The following is a description of a gene set: Human Gene Set: GSE2770_TGFB_AND_IL4_VS_IL4_TREATED_ACT_CD4_TCELL_6H_DN from publication Lund R, Aittokallio T, Nevalainen O, Lahesmaa R (PMID 14607935) species: Homo sapiens Th1 and Th2 cells arise from a common precursor cell in response to triggering through the TCR and cytokine receptors for IL-12 or IL-4. This leads to activation of complex signaling pathways, which are not known in detail. Disturbances in the balance between type 1 and type 2 responses can lead to certain immune-mediated diseases. Thus, it is important to understand how Th1 and Th2 cells are generated. To clarify the mechanisms as to how IL-12 and IL-4 induce Th1 and Th2 differentiation and how TGF-beta can inhibit this process, we have used oligonucleotide arrays to examine the early polarization of Th1 and Th2 cells in the presence and absence of TGF-beta after 0, 2, 6 and 48 hours of polarization. Genes down-regulated in CD4 T cells activated by anti-CD3 and anti-CD28: TGFB1 and IL4 (6h) versus IL4 (6h)., and this is the list of marker genes: USP8, ENPP2, BAK1, NIPA1, PCDHA9, TP53INP2, SCO1, TNFRSF1A, RRAGD, NUP54, PHLDA1, AMD1, TAF13, B4GALT5, NUP43, RRP1, IDH3A, WDR46, TUBA1B, SMAP2, DAPK3, DNAJB4, SOD1, MOB3A, EEIG1, EMSY, GTF2H1, BORCS6, MSMO1, EBP, ATP5IF1, RPAP3, CHST12, UAP1L1, LCORL, ZNF141, MXI1 (NCBI Gene Id 4601), SIVA1, HSPA14, ARID4B, PEA15, TOP2A, OTULIN, CHUK, CDC34, FBXW7, SPPL3, ZUP1, DNAJC5, MTHFR, ISL2, MED17, UNG, TNFRSF10B, TUBA3C, PRKACA, NOP9, ABHD4, NDRG1, DLEU1, AHCTF1, BSG, ZNF441, GADD45G, SNAI3-AS1, YBX3, RGS1, CYP2U1, STK40, PAFAH1B2, EIF5A2, LYSMD2, PGK1, KLHL25, ADPRS, CEP43, FAM98B, FAM177A1, FLT1, NET1, SSX2IP, USP47, NAMPT, QSER1 (glutamine and serine rich 1), SNX30, MASTL, AIMP2, SERAC1, TENT4B, RIOK2, SRP54, SV2A, MFSD14B, SNAPC3, AVIL, PPIF, TASOR2, ASF1A, LITAF, CAND1, RBM14, VCPKMT, ALKBH1, INSIG2, TCF7L2, LRPAP1, SCO2 (NCBI Gene Id 9997), CMTM6, PPP2CB, TAF1D, LINC02693 (NCBI Gene Id 339263), LONP1, RC3H1, FBXW11, APAF1, DAG1, SYNM, TOPORS (TOP1 binding arginine/serine rich protein, E3 ubiquitin ligase), IDS, ATP6V1E1, SAP30L, DLEU2, TNFRSF9, COMMD5, ELOF1, LEMD3, NAA35, H2BC8, PSMA6, CNIH4, ZNF253, USP9X (NCBI Gene Id 8239), ARHGAP17, GABARAPL2 (NCBI Gene Id 90769), RBAK, MAK16, CHAC2, DLD, WDR47, C1QBP, NUP133, ELOA, HBP1, AFTPH, STK38L, TRIAP1, PPME1, PURA, GTPBP4, PPP2R2A, CAPRIN1, STIP1, PLAUR, CEP350, NCBP1, ATP6V0A2, URB1, RELCH, UTP6, POLR3H, PRDX2, ZNF267, TOR1B, GON7 (GON7 subunit of KEOPS complex), ZNF17, CRIPT, SNHG16, SPTSSA, PRRT3, PGP, PI4K2B, TOLLIP, TENT5A, DIPK1A (divergent protein kinase domain 1A), RANBP2, PHF20, SMIM29, AKAP1, SRA1, DNAJA2, RNF40, CREG1, CDK2, RNASEK, FAM13B, AHDC1, ULK4, MCMBP, SUMO1, MPC2, KIF2A, PREB, ING2, GLRX3, KIF1B, ZDHHC3, NOL6, RMND5A